Given this list of marker genes STX19, PRRT2, STX1B, SNAP23, RPH3A, ERC2, CPLX1, CPLX4, SYT7, SNAP47, SYT8 (NCBI Gene Id 90019), RPH3AL, SYNGR1, SNAPIN, SYP (NCBI Gene Id 6855), SNAP29, STX2, SYT9, SYNGR2, DOC2B, STX11, SNAP25, SYT1, AP3D1, SYT5, SYT11, SYT2, CPLX2, SYT4, GRIK5, STXBP1, RAB3A, SYT13, TOR1A, CPLX3, DOC2A (double C2 domain alpha), here is a description of the gene set: A process that is carried out at the cellular level which results in the assembly, arrangement of constituent parts, or disassembly of the membrane surrounding a synaptic vesicle. Human Gene Set: GOBP_SYNAPTIC_VESICLE_MEMBRANE_ORGANIZATION studied in species Homo sapiens